The following is a description of a gene set: Genes significantly down-regulated in the high-risk Molecular Risk Stratification (MRS-3) hepatoblastoma (HB) as compared with intermediate-risk (MRS-2) and low-risk (MRS-1) molecular HBs, assessed by Human Transcriptome Array (HTA). Background & Aims: Hepatoblastoma (HB) is a rare disease. Nevertheless, it is the predominant pediatric liver cancer, with limited therapeutic options for patients with aggressive tumors. Herein, we aimed to uncover the mechanisms of HB pathobiology and to identify new biomarkers and therapeutic targets in a move towards precision medicine for patients with advanced HB. Human Gene Set: CARRILLOREIXACH_MRS3_VS_LOWER_RISK_HEPATOBLASTOMA_DN studied in species Homo sapiens from publication Carrillo-Reixach J, Torrens L, Simon-Coma M, Royo L, Domingo-Sàbat M, Abril-Fornaguera J, Akers N, Sala M, Ragull S, Arnal M, Villalmanzo N, Cairo S, Villanueva A, Kappler R, Garrido M, Guerra L, Sábado C, Guillén G, Mallo M, Piñeyro D, Vázquez-Vitali M, Kuchuk O, Mateos ME, Ramírez G, Santamaría ML, Mozo Y, Soriano A, Grotzer M, Branchereau S, de Andoin NG, López-Ibor B, López-Almaraz R, Salinas JA, Torres B, Hernández F, Uriz JJ, Fabre M, Blanco J, Paris C, Bajčiová V, Laureys G, Masnou H, Clos A, Belendez C, Guettier C, Sumoy L, Planas R, Jordà M, Nonell L, Czauderna P, Morland B, Sia D, Losic B, Buendia MA, Sarrias MR, Llovet JM, Armengol C (PMID 32240714), and this is the list of marker genes: EGR3, SEL1L3, ARID5B, GGTA1, PTPN13, RGS4, RGL1, RGS2, OMD, MYOCD, ADAMTS9-AS2, DMD (NCBI Gene Id 548327), PAG1, PDGFRA, TMSB4X, ARHGAP10, CLIC4, NEXN, SH3BGRL, DPT, DDR2 (discoidin domain receptor tyrosine kinase 2), STK38L, CLEC2B, TLR7, CH25H, SLC9A9, PRELP, ABI3BP, RNF150, RRAS, ETS1, PRKACB, PCDH7, CTSK, GNB4, LUM (lumican), MSR1, JUNB, MSRB3, JAM3, JHY, SSBP2, EPHA3, CYRIA (CYFIP related Rac1 interactor A), FILIP1L, PDCD1LG2, ARHGEF10, LGALS3 (galectin 3), ACER3 (alkaline ceramidase 3), ADAMTS1, TIMP2, EPB41L2, PRDM1, SEPTIN7, ZNF438, EMP1, GLT8D2, MFAP4, MEF2C, MOB3B, LBH, TM6SF1, MS4A4A, NR4A3, MB21D2, SWAP70, SLC24A3, HSPB8, ASAH1, PDE4B, MGP, SLIT2, SLC25A24, FCGR2C, SETBP1, PTGS2, ANK3, EEIG2, ARMCX1, NFASC, PPP1R12A, AEBP1, ANXA1, BHLHE41, STK17B, GPRIN3, SPIRE1 (NCBI Gene Id 56907), SH3RF1, FAP, ITPRIP, OSBPL8, ZSWIM6, PMP22, DCN, FCGR2A (NCBI Gene Id 90764), MAP3K5, OSTF1, PRKG1, DNM3OS, TMEM47 (transmembrane protein 47), GLIPR1, CD9, P3H2, PDE3A, TLR4, PCDHGB7, NIBAN1, MBOAT1, CRYBG3, CCL2, CCN1, FGF7, HECA, OSBPL1A, CTTNBP2NL, IFI16, BCL2, PLA2R1, RHOQ, PLXDC2, CYBRD1, GPNMB, ZEB2, FPR3, SAMD9, ODF2L, LHFPL6, LRCH2, SMIM10, RHOQP3, HLA-DPA1, RSU1, RARB, RBMS3, MITF, TCF4, LINC00924, VIM, MAML2, MAMDC2, RERG, CD200, TANC2, FAR1, ARHGEF6, LTBP1, RAB31, RASSF2, EDNRA, TGFB1, ZFPM2, CSGALNACT2, HACD4, CCDC71L, ANTXR1, MIR23AHG, SAMD9L, MYO5A, RFTN1, MSC-AS1, KCTD12, AXL, KCNE4, SGCD, AKT3, SYNPO2, IQGAP1, GEM